Given this list of marker genes OR10J1, KLK5, INO80B, SPINDOC, SCEL, OR2F2, SLC27A6, SYT9, ALMS1, GRIN2B, H1-7, TTC21B, MIF-AS1, GAP43, FGL1, GPR37, ZFP14, BLM, SELE, AMH, MIR4290HG, KCNH1, RTN4RL1, KRTAP4-6, DKK2, MRNIP, PRR15 (proline rich 15), HAND1, EHBP1, LYPD6B, MYL4, KRT86 (NCBI Gene Id 650428), RNF207, F2R, LINC02510, PTPRF, IL23A, ALB, TGFBRAP1, OGDHL, CCDC116, ITM2C, ARHGEF34P, KRTAP9-8, PDGFRB, LINC01193, CD247, TBX1, CHRD, SNAP25, TOB1-AS1, ADPRHL1, PACS2, PHF21B, CSAD, ZNF607, WDR11-DT (WDR11 divergent transcript), COL26A1, NODAL, CEACAM19, GLT1D1, GDF11, LRRC61, KRT2, NLRP12, OR1C1, PLK5, SFRP4, PTH1R, MTCL3, ASMT, ARMH1, PARD3, PNLIPRP1, RNFT2, PLXDC1, MLPH, DLK2, SSPN, CT45A5, LINC01973, C8orf44, LINC00658, CEP152, CHADL, ZNF141, SCAMP5, CADM4, FBXL19-AS1, ADGRB3 (adhesion G protein-coupled receptor B3), CPB1, CHAF1B, MAPK11, ZNF70, SCUBE2, KCNA2, LRRC3, SORCS1, VEPH1, THEMIS, MAPT, FBF1, ADAM18 (NCBI Gene Id 8749), LZTS1, DZANK1, DNM1P46, LINC02685, IRAG2, LILRA4, ANKRD20A11P, LRIT1, SLC4A11, FAM228B, SCAMP1-AS1, CLCA1, SMAGP, DACH2, SLC30A2, LINC02532, IQCF5, CA1, CEP295, ITFG2, DNAAF1, MUC17, FZD10-AS1, LINC02825, VWCE, MESP1, RHD, MIR646HG, LAMB4, NHLH1, MIOX, PHGDH, ANO8, NSUN6, TP53TG5, NCR1, DEUP1, APBB1, AMER2, CXCL17, SHISA9, ERLEC1P1, TIGD4, KLF14, ERC2-IT1, LINC02210, EFNA1, ALG10, LINC00173, ANKRD24, NLE1, TMC5, TAF7L, PARD6G, TEX38, MIR137HG, ABCA17P, KLHL4, ZSCAN20, LGI2, KIF26A, KRT76, PROCR, FMR1NB, PCDHB7, SMYD3, LCN12, C20orf173, RNF180, MYRF-AS1, PARP3, SH3GL1P2, THY1, PODN, AVP, TMEM132B, ADGRG4, ACKR2, RUSC1-AS1 (NCBI Gene Id 284618), BCAS3, WWTR1-AS1, GYPA, NRXN3, CBX2, GOLGA6L2, PARD6B, MYBPH, TPTE2P6, here is a description of the gene set: Human Gene Set: GSE41867_DAY8_VS_DAY15_LCMV_ARMSTRONG_EFFECTOR_CD8_TCELL_UP species: Homo sapiens Genes up-regulated in CD8 T effectors at acute infection with LCMV-Armstrong: day 8 versus day 15. During acute viral infections, naïve CD8+ T cells differentiate into effector CD8+ T cells and, after viral control, into memory CD8+ T cells. Memory CD8+ T cells are highly functional, proliferate rapidly upon reinfection and persist long-term without antigen. In contrast, during chronic infections, CD8+ T cells become “exhausted” and have poor effector function, express multiple inhibitory receptors, possess low proliferative capacity, and cannot persist without antigen. To compare the development of functional memory T cells with poorly functional exhausted T cells, we generated longitudinal transcriptional profiles for each. from publication Doering TA, Crawford A, Angelosanto JM, Paley MA, Ziegler CG, Wherry EJ (PMID 23159438)